The following is a description of a gene set: species: Mus musculus A dispersed and relatively uncompacted form of chromatin that is in a transcription-competent conformation. Mouse Gene Set: GOCC_EUCHROMATIN, and this is the list of marker genes: Ice1, Gm6421, Myc, Jun, Exosc3, Esr1, Skic3, Rbmxl1, Ppargc1a, H3f3a-ps1, Cbx3, Tcf3, H1f4, Exosc10, Rrp1b, H1f0, Smarca4, Pelp1, Prdx1, Vdr, Myod1, Aff4, H2az1, Cbx2, H3f5, Sp1, Rbmx, Trim28, Ankrd2, Nr1h4, Tcf23, Skic8, Bcas3, Uhrf1, Ruvbl2, Id2, Nsmf, H2ab1, Gm10257, H1f3, Sirt1, Polr2a, Dntt, Ctnnb1, Ctr9, Dnmt3a, H1f5, H3f3c, Setd5, Ell, Tbp, Klf4, Tcf7, Exosc5, H1f1, Ash2l, Creb1, Zc3h8, Pou4f2 (POU domain, class 4, transcription factor 2), Kmt2e, Padi2, Hsf1, Psip1, H2ab3, Cecr2, Ice2, H1f2, Hif1a, Alkbh1, Trnp1, Exosc4, Rnf2 (ring finger protein 2), Ogt, Jak2, Trim24, Setd1a, H2ab2